Given this list of marker genes Ube2s, Ube2srt, Plk1, Cdc20 (cell division cycle 20), Cdc20b, Pten, Ccnf, Fbxo5, Fzr1, Clspn, here is a description of the gene set: species: Mus musculus Binding to an anaphase-promoting complex. A ubiquitin ligase complex that degrades mitotic cyclins and anaphase inhibitory protein, thereby triggering sister chromatid separation and exit from mitosis. Mouse Gene Set: GOMF_ANAPHASE_PROMOTING_COMPLEX_BINDING